The following is a description of a gene set: studied in species Mus musculus The directed movement of a tripeptide, a compound containing three amino acids linked together by peptide bonds, into, out of or within a cell, or between cells, by means of some agent such as a transporter or pore. Mouse Gene Set: GOBP_TRIPEPTIDE_TRANSPORT, and this is the list of marker genes: Slc15a2, Mgst1, Abcc1, Abcc5, Gja1, Abcc2, Slc25a40 (solute carrier family 25, member 40), Nherf1, Slc15a1, Abcc4, Slc25a39, Slc13a3, Slc22a8, Slc7a11